The following is a description of a gene set: species: Homo sapiens The activation signaling of transcription factor nuclear factor-kB (NF-kB) plays central role for immune system. One of key kinase mediating this pathway is TAK1 in adaptive and innate immunity. However, role of TAK1 in B cell receptor signaling is still unclear. To know effects of TAK1-deletion on the gene expression induced by anti-IgM, we performed the time course analysis in comparison of wild type with TAK1-deleted splenic B cells. Genes up-regulated in B lymphocytes treated by anti IgM for 24h: wildtype versus MAP3K7 knockout. from publication Shinohara H, Behar M, Inoue K, Hiroshima M, Yasuda T, Nagashima T, Kimura S, Sanjo H, Maeda S, Yumoto N, Ki S, Akira S, Sako Y, Hoffmann A, Kurosaki T, Okada-Hatakeyama M (PMID 24833394) Human Gene Set: GSE41176_WT_VS_TAK1_KO_ANTI_IGM_STIM_BCELL_24H_UP, and this is the list of marker genes: ANXA2, TUBB2A, HPCAL1, ME2, HRAS, FICD, CNTN6, PHF1, PCYT1A, JAG1, TUBB4A, EMP1, SLC6A8, GLA, SMARCD3, ASPH, ARIH1, NDEL1, MAPK7, SLC39A7, PITPNM1, GMPS, ULK1, EZR, GADD45A, SETD3, TLK1, CYTH2, PLEKHM2, CDKN1C, BMP6, MANF, TPI1, SLC10A3, GSR, TRIM16, SERTAD2, HMGA1, ATG4B, KDELR2, LST1, NDUFS7, SQSTM1, RABAC1 (NCBI Gene Id 10567), SPAG9, VAMP3, SFN, JMJD1C, HOMER3, HMOX1, ERF, IL1RAP, RHOB, UGDH, SLC25A1, IP6K1, CLIP1, ODC1, PGD, NQO1, STX5, CREG1, VDAC3, CD302, SEC16A, PLEKHO2, ZNF516, TFE3, LY86, ECI1, HTATIP2, TESK1, KLHL21, TDP2, FLNB, TSPAN4, HSPA5, KCTD7, FEM1C, MTCL2, PSMD7, EPS8, FNDC3A, PPARG, CAPNS1, RNF103, CDS2, JMJD6, CKS2, DUSP1, CA2, FOS, MAPKAPK2, AGO2, ZFAND5, YWHAQ, PPIF, PRCP, DEGS1, ATP6V0D1, FADS1, RNF4, MEF2D, UBTF, SLC6A6, RNH1, RIT1, GGA2, TSPYL2, OAT, TUBB3, ATF2, CAMSAP1, HYOU1, UBN1, CNPY3, PGM3, GFPT1, DNAJB9, TMEM41B, UBE2S, GBE1, MIR22HG, AKAP17A, POR, MOAP1, GOLGA2, IDS, STRN, TUBB4B, CD163, NUCB1, SRSF3, KLC1, UBE2H, ADM, PCSK5, ZFP36L1, HIC2, WIPI2, KIAA0232, IL6ST, MGAT1, PTOV1, RAB5B, TKT, RALY, PITPNA, GCLM, BLVRB, BCAR3, MCFD2, FAH, AFG3L2, BCAP31, TXNRD1, JOSD1, ADRM1, SLC3A2, VCP, HDLBP, GCLC, TSPO, SERINC5, NRG1, FAU, GRB10, FAM89B, RHOC, ATP6V0C, HDAC5, JUN, ASMTL, ZBED4, FOSL1, MEIS3P1, RYBP, UBE2D2, KDELR1, TRIM2, AHNAK, BAHD1, MTFR1, RRBP1, KEAP1, TRIB1, EFHD1, ACSL3, TPST2, PLEKHM1, GORASP2, LMNA, ACVR1, YWHAZ, PDIA4, SOD1, TBXAS1, CDKN3, ARF5, CNPPD1